Given this list of marker genes Xcl1, Cd200r1, Selenok, Apod, Cxcl10, Ripk3, Wnk1, Wnt5a, Ccl20, Tnfsf4, Spn, Aif1, Rhoa, Ecm1, Cxcl12, App, Dock8, Adam10, Stk39, Fadd (NCBI Gene Id 14082), Itga4, Adam8, Adam17, Crk, Il27ra (interleukin 27 receptor, alpha), Ccl5, Ccr6, Ascl2, Ccl21a, Ripor2, Cxcl13, Cd69, Gpr15lg, Coro1a, Aire, Itgb3, P4hb, Tnfrsf14, Tmem102, Abl2, Tnfsf14, Ccr7, Spns2, Lgals9, Crkl, Oxsr1, Pycard, Lrch1, Cd200, Abl1, Med23, Cd99l2, Ccr2, here is a description of the gene set: studied in species Mus musculus Any process that modulates the frequency, rate or extent of T cell migration. Mouse Gene Set: GOBP_REGULATION_OF_T_CELL_MIGRATION